Given this list of marker genes FGF1, VNN1, SDC4 (syndecan 4), CYP4A11 (cytochrome P450 family 4 subfamily A member 11), NOCT, RAB30, HSD3B1, HSPH1, EHHADH, HSD17B11, SERPINA3, RAD51B, PNPLA7, ACOT2, FABP2, RETSAT, ACOT1, APOA4 (apolipoprotein A4), SDS, BDH1, CYP7B1, ATF5, IGF1, here is a description of the gene set: from publication Weng Y, DiRusso CC, Reilly AA, Black PN, Ding X (PMID 16006652) studied in species Mus musculus Human Gene Set: WENG_POR_TARGETS_LIVER_DN Genes down-regulated in liver from mice with liver specific knockout of POR. NADPH-cytochrome P450 reductase (CPR) is an essential component for the function of many enzymes, including microsomal cytochrome P450 (P450) monooxygenases and heme oxygenases. In liver-Cpr-null (with liver-specific Cpr deletion) and Cpr-low (with reduced CPR expression in all organs examined) mouse models, a reduced serum cholesterol level and an induction of hepatic P450s were observed, whereas hepatomegaly and fatty liver were only observed in the liver-Cpr-null model. Our goal was to identify hepatic gene expression changes related to these phenotypes. Cpr-lox mice (with a floxed Cpr gene and normal CPR expression) were used as the control. Through microarray analysis, we identified many genes that were differentially expressed among the three groups of mice. We also recognized the 12 gene ontology terms that contained the most significantly changed gene expression in at least one of the two mouse models. We further uncovered potential mechanisms, such as an increased activation of constitutive androstane receptor and a decreased activation of peroxisomal proliferator-activated receptor-alpha by precursors of cholesterol biosynthesis, that underlie common changes (e.g. induction of multiple P450s and suppression of genes for fatty acid metabolism) in response to CPR loss in the two mouse models. Additionally, we observed model-specific gene expression changes, such as the induction of a fatty-acid translocase (Cd36 antigen) and the suppression of carnitine O-palmitoyltransferase 1 (Cpt1a) and acyl-CoA synthetase long chain family member 1 (Acsl1), that are potentially responsible for the severe hepatic lipidosis and an altered fatty acid profile observed in liver-Cpr-null mice.